The following is a description of a gene set: Human Gene Set: GOBP_GABAERGIC_NEURON_DIFFERENTIATION species: Homo sapiens The process in which a neuroblast acquires the specialized structural and functional features of a GABAergic neuron., and this is the list of marker genes: DRD2, NKX2-1, FEZF2, HELT, CNTN2, DLX2, GSX2, BCL11B, PRDM13, ASCL1, DLX1, LHX6, TLX3, INHBA, RAC1, GATA2, RAC3, DRD1, ZSWIM6, SHANK3, ARX